Given this list of marker genes Tbpl1, Nme3, Tyms, Nme6, Cad, Nme7, Nme5, Nme1, Cmpk2, Dtymk, Uck1, Ctps1, Uck2, Ctps2, Nme4, Nme2 (NME/NM23 nucleoside diphosphate kinase 2), here is a description of the gene set: The chemical reactions and pathways resulting in the formation of pyrimidine nucleoside triphosphate, a compound consisting of a pyrimidine base linked to a ribose or deoxyribose sugar esterified with triphosphate on the sugar. species: Mus musculus Mouse Gene Set: GOBP_PYRIMIDINE_NUCLEOSIDE_TRIPHOSPHATE_BIOSYNTHETIC_PROCESS